The following is a description of a gene set: We have carried out global gene expression analysis to clarify the interrelationship between 1,25-dihydroxyvitamin D3 and differentiation-driven gene expression patterns in developing human monocyte-derived dendritic cells. Monocytes were treated with 10 nM 1,25-dihydroxyvitamin D3 or vehicle 14 hours after plating for 12 hours or 5 days. Monocytes, differentiating dendritic cells (+/-1,25-dihydroxyvitamin D3 for 12 hours) and immature dendritic cells (+/-1,25-dihydroxyvitamin D3 for 5 days) were harvested. This design allows one to identify genes regulated by differentiation and/or 1,25-dihydroxyvitamin D3 in human monocyte-derived dendritic cells. Human Gene Set: GSE13762_CTRL_VS_125_VITAMIND_DAY12_DC_DN studied in species Homo sapiens Genes down-regulated in dendritic cells (12 days): control versus 25-hydroxyvitamin D3. from publication Széles L, Keresztes G, Töröcsik D, Balajthy Z, Krenács L, Póliska S, Steinmeyer A, Zuegel U, Pruenster M, Rot A, Nagy L (PMID 19201860), and this is the list of marker genes: MYL2, RAP1A, KIF15, SGCZ, CLSPN, POLL, GPC4, PKD2L1, MATN2 (NCBI Gene Id 4147), NUDCD1, CCDC92, IDO1, HRC, CASTOR2 (NCBI Gene Id 730322), JPH1, GNL2, CXCL3, NOL11, SYT14, SCN1A, LY6G5B, MANF, CFAP36, GJE1, SLC7A4, PPFIBP1 (PPFIA binding protein 1), PPP2R5B, ALDH9A1, GSDMC, THSD1, RAB44, LRRC8C, KIF13A, INTS3, NOTUM, KIFAP3, FAM222B, PFN4, SHOC2, C14orf39, EPM2A, ADGRG5, TRPV1, FRK, RAB10, SLC27A4, AP2M1, UBAP2, VEGFC, ADAM30 (NCBI Gene Id 11085), TBATA, KIF4A, GTPBP4, AP2B1, TOPBP1, MUCL1, CAVIN4, ADAMTS4, HFE, TGM4, S100A13, CSTL1, APOF, TOP2A, GABRB2, SAXO1, ENDOD1, KRT24, CEP192, PTN, AIDA, NEB, FAM163B, TLNRD1 (NCBI Gene Id 59274), PLOD1, EPYC, FNIP2, PLCD1, POLR2M, EFCAB5, FGF6, GOLIM4, CCT2, CRIP3, CYP2W1, GPR34, MIR451A, GRIA1, NEK7 (NIMA related kinase 7), ACTL6B, PLCXD1, ANK1, HDAC10 (NCBI Gene Id 83933), DARS1, NBEA, CTXN3, BTBD10, PATL2 (PAT1 homolog 2), ASB9, SPATA20, CDK2, NAMPT, COQ8B (coenzyme Q8B), SDC4, SPINK2, FRMD5, ONECUT2, SPIRE1, LMBR1, NUP133, ENPEP, PTGDR, LDLRAD1, TBC1D12, BCAP29, THBS1, XCL1, RXFP4 (relaxin family peptide/INSL5 receptor 4), NXPH2, EXO1, PHLDA1, MFSD2A, RPUSD2, DCN, CYP1A1, PRSS41, S100A9, LMNB2, GLB1L3, NUCB2, ADCY10, HSD17B13, B3GNT9 (NCBI Gene Id 84752), NCAPG